The following is a description of a gene set: Mouse Gene Set: chrXA4 studied in species Mus musculus, and this is the list of marker genes: Gm7189, Gm7722, Gm14576, Gm6480, Gm14615, Dcaf12l1, Itpa-ps3, Actrt1, Gm14580, Tex13c1, Gm5135 (NCBI Gene Id 386568), Gm7700, Gm14575, Prr32, Gm14578, Sh2d1a, Gm4986, Stag2, Gm5386, Gm7190, Gm14609, Gm14613, Tex13d, Gm14603, Gm4908, Gm24763, Gm14652, Gm14577, Tenm1, Gm5385, Gm14579, Gm14610, Gm14606, Gm14614, Thoc2, Gria3, Gm14628, Gm14653, Gm7657, Gm23705, Dcaf12l2, Xiap, Gm14608, Gm4987, 4930515L19Rik